The following is a description of a gene set: from publication Yang HT, Wang Y, Zhao X, Demissie E, Papoutsopoulou S, Mambole A, O'Garra A, Tomczak MF, Erdman SE, Fox JG, Ley SC, Horwitz BH (PMID 21217011) species: Homo sapiens Human Gene Set: GSE19941_UNSTIM_VS_LPS_AND_IL10_STIM_IL10_KO_NFKBP50_KO_MACROPHAGE_UP Genes up-regulated in IL10 and NFKB1 knockout macrophages: unstimulated versus stimulated by IL10 and LPS. Bone marrow-derived macrophages were produced from mice lacking IL-10 alone (IL10-def) or mice lacking both IL-10 and the p50/p105 subunit of NF-kB (p50/IL10), and left unstimulated, stimulated with LPS (1 ng/ml) or stimulated with LPS and IL-10 (0.3 ng/ml)., and this is the list of marker genes: BTBD16, SPON2, FOXH1, SSTR1, FGF11, PSEN2, HAP1, ENGASE, PRRT3, MRC2, SETD7, TENT5B, KLHL24, CD80, AIG1, RSAD2, TOX, PDLIM4, GPRIN3, PCDH12, FAM181A, SLC16A5, NTSR1, OPLAH, ALX4, SLC43A1, CORO2B, MIR129-1, RREB1, NISCH, ANKRD55, OBSL1, LHFPL1, AIFM3, GPR183, STOML1 (NCBI Gene Id 9399), RPL23, IQCC, MCOLN2, GCOM1 (GCOM1, MYZAP-POLR2M combined locus), PHF21A, SNX9, ZRSR2P1, S1PR1, KRT31, SEZ6L, ANKK1, SMYD1, CXCR3, ITGA7, PLCB2, VEGFA, PROCA1, PPP2R2A, EXOC3L1, EMILIN1 (NCBI Gene Id 25883), PTOV1, ADK, RNF167, SHANK1 (SH3 and multiple ankyrin repeat domains 1), C2orf69, SPAG4, RPL37A, C6orf118, HLA-B, MTLN, PAWR, USP8, DPP10, ADGRG1, SCRN2, EGLN3, IGFBP7, GNL2, CLEC3B, S100A7A, ACTN2, PMEPA1, EGR2, CD27, DNAJB5, FRAT2, SLC6A19, ATP6V1B1, NCOA1, SNORA20, CASP9, ARMC7, HCN4, SLC25A29, TNP1, INPP4B, NPTX2, CCDC65, MGAT5B, BCAP29, FRAT1, HNF1A, SDCBP2, APOBEC1, FBLN7, USP45, DTNB, SHPK, FGD5, LGI4, AMER3, PDCD1, CDCP2, RGS9BP, ADAM19, ACAD10, HEXA, TRMO, WFS1, FAS, NSG2, TANC2, CDYL2, EML5, HECTD2, CXCR5, PMM2, PRXL2A, PRKCB, PRAM1, SURF2, VIPR1, GALNT11, CCR7, CRIM1, RHOH, ACTN1, QPRT, ACTR6, SH3D21, EID2, MAP4K5, RUNDC3A, GLRA1, PACSIN1, AIM2, CEACAM16, TOMM20, CDKN1B, MXRA8, ART3, GPX3, PAIP2, SDK1, HELT, SNORA28, RPL11, PHLDB3, KCNMB4, FBXO6, NTNG1, DNAJB13, GSG1L, DUS4L, PTPN2, DNAJC4, UQCC1, MARCHF7, FTH1 (ferritin heavy chain 1), PDGFB, PRTN3, PNRC2, RPS27, GMFG, TENT5C, PLEKHA6, BICDL1, IFNAR2